The following is a description of a gene set: Mouse Gene Set: CUI_T_CELL_CD8_IL36A_RESPONSE_UP Cytokines mediate cell-cell communication in the immune system and represent important therapeutic targets. A myriad of studies have highlighted their central role in immune function, yet we lack a global view of the cellular responses of each immune cell type to each cytokine. To address this gap, the authors created the Immune Dictionary, a compendium of single-cell transcriptomic profiles of more than 17 immune cell types in response to each of 86 cytokines (>1,400 cytokine-cell type combinations) in mouse lymph nodes in vivo. A cytokine-centric view of the dictionary revealed that most cytokines induce highly cell-type-specific responses. For example, the inflammatory cytokine interleukin-1β induces distinct gene programmes in almost every cell type. A cell-type-centric view of the dictionary identified more than 66 cytokine-driven cellular polarization states across immune cell types, including previously uncharacterized states such as an interleukin-18-induced polyfunctional natural killer cell state. studied in species Mus musculus Genes positively differentially expressed in cell type: CD8+ T cell upon treatment with cytokine: IL-36α in mouse lymph nodes in vivo. from publication Cui A, Huang T, Li S, Ma A, Pérez JL, Sander C, Keskin DB, Wu CJ, Fraenkel E, Hacohen N (PMID 38057668), and this is the list of marker genes: Gbp9, U2af1, Cyc1, Rexo2, Eef1e1, Hnrnpa3, Ms4a4c, Hdgf, Shmt2, Lap3, Irf8, Atp5f1b, Snrpf, Sf3b5, Set, Psma3, Mrpl21, Stat2, Cct3, Rrp9, Ybx3, Larp1, Glrx3, Mphosph10, Anp32e (acidic nuclear phosphoprotein 32 family member E), Tomm5, Polr2f, Cycs (NCBI Gene Id 13063), Mdh2, Lsm7, Phb2, Hspd1, Eif4a1, Chchd1, Notch1, Hnrnpd, Atp5mk, Ppan, Psmb5, Gbp6, Gbp4, Strap, Psmg4, Icam1, Ndufa5, Tap1, Eif5a, Eif4ebp1, Lsm6, Eloc, Pole4, Nop56, Ptges3, Nudc, Glrx5, Wars1, Psmd14, Bzw2, Psmb6, Psmb8, Eif1ax, Ifi208, Clic4, Snrpd1, Elob, Fam162a, Mrpl52, Erap1, Hnrnpu, Pa2g4, Psmd7 (NCBI Gene Id 17463), Hspa8, Atic, Anp32b, Ywhae, Erh, Mrps28, Slc25a5, Vars1, Nifk, Timm9, Eif1a, Phgdh, Eprs1, Hsp90aa1, Rsl24d1, Ndufb2 (NCBI Gene Id 98925), Cox5b, Psat1, Ebna1bp2, Pes1, Psma4, Serbp1, Cxcl10, Dbnl, Slc7a1, Nop16, Igtp, Cd82, Cct5, Tap2, Isg15, Ddx21, Srsf3, Bst2, Ube2l3, Zfp593, Xaf1, Ifit1, Cox7c, Uchl3, Hspa5, Isg20, Mrto4, Rtp4, Dph3, Nfkbia, Tpm3, Nasp, Wdr43, Rars1, Naa20, Ifi47, Uqcr10, H2-Q4, Tuba4a, Lyar, Hspa4, Npm3, Cltb, Dkc1, Abce1, Ndufs6, Gpr18, Ube2m, Irf7, Snrpe, Eif2s2 (NCBI Gene Id 99435), Denr, Ran, Psme2, Znrd2, Ndufb4, Timm50, Pebp1, Nop2, Socs3, Mrpl51, Etf1, Irgm1 (NCBI Gene Id 15944), Eny2, Sarnp, Stat3, Eif3a (NCBI Gene Id 320318), Slc3a2, Pdcd11, Fkbp4, Llph, Vasp, Hsp90ab1, Dnaja2 (DnaJ heat shock protein family (Hsp40) member A2), Srsf7, Ppig, Eif3j1, Mrpl20, Mthfd2, Top1, Chmp4b, Calhm6, Caprin1, Cks2, Sp110, Eif3g, Dnajc2, Agfg1, Irf1, Lsm4, Gbp5, Txnl4a, Cct2, Snrpa1, Cacybp, Trafd1, Canx, Plac8, Tomm40, Pim1, Rsl1d1, Tnfrsf9, Sars1, Utp18, Bzw1, Gar1, Snrpd3 (NCBI Gene Id 78379), Ppp1r16b, Prmt1, Nampt, H2-T23, B2m, Edf1, Mat2a, Mif, Atp1a1, Gtf2f1, Romo1, Slc29a1, Samhd1, Arpp19, St13, Emc6 (NCBI Gene Id 70341), Mydgf, Gspt1, Kars1, Nme1, Psmb10 (NCBI Gene Id 19171), Srsf2, Mrpl17, Psmc5, Ccnd2, Nlrc5, Pgam1, Tkt, Mrpl36, Smc1a, Cox7b, Mettl1, Chchd2, Eif2ak2, Mrpl23, Gbp2, Cnbp, H2-K1, Ifi206, Tcp1, Tgtp1 (T cell specific GTPase 1), Ssrp1, Ssb, Pbdc1, Wdr83os, Lars1, Ppp1r14b, Eif5b, Aars1, Nhp2, Batf, Herc6, Prpf31 (NCBI Gene Id 70126), Ddx24, Mrpl19, Eif3b, Rrp1b, Sem1 (SEM1, 26S proteasome complex subunit), Rbmxl1, Ranbp1, Ly6e, Gbp8, Parp14, Tuba1b, Kcnq1ot1, Parp9, Mitd1, Trim12c, Nip7, Pals2, Psma5, Gzmb, Aurkaip1, Ndufab1, Alyref, Rbx1, Tmem167, Phb1, Ifrd2, Ybx1, Psmb9, Bax, Sumo2, G3bp1, Nop10, Cd274, Ltv1, Nars1, C1qbp, Pcbp1, Bccip, Mdn1, Pfdn2, Ldha, Aimp2, Eif6, Yars1, Ahsa1, Ifi35, Timm10, Mrpl30 (mitochondrial ribosomal protein L30), Cebpz, Pdap1, Sap18, Ptma, Lsm12, Prdx1, Odc1, Atad3a, Mndal, Nop14, Wdr12 (NCBI Gene Id 80478), Eif1 (NCBI Gene Id 217191), Ndufaf4, Ifi27l2a, Stat5a, Cars1, Gstp1, Uqcrq, Arid5b, Eif4g1, Oas3, Mapkapk2, Fabp5, Rbm8a, Mrpl12 (NCBI Gene Id 69758), Srm, Ddit3 (NCBI Gene Id 13198), Apex1, Pdcd5, Gnl3 (NCBI Gene Id 30877), Snrpb, Cops6, Bola2, Igfbp4, Ruvbl1, Ufm1 (NCBI Gene Id 99652), U2af2, Dtx3l, Lgals3bp, Tcof1, Tcf7, Cfdp1, Tars1, Eif4e, Noc2l (NOC2 like nucleolar associated transcriptional repressor), Atp5f1d, Psmd12, Aprt, Gpatch4 (G patch domain containing 4), Psma6, Ppia, Psma1, Rrs1, Pomp, Cct8, Ksr1 (kinase suppressor of ras 1), Fbl, Srsf6, Cdk6, Ftsj3, Mars1, Tmed5, Atp5mc1, Krtcap2, Atf4, Timm8a1, Hnrnpa2b1, Lman2, Snu13, Cox5a, Dcun1d5, Grpel1, Birc3, Lamp2, Gbp7, Dctpp1, Iigp1 (NCBI Gene Id 73042), Rcc2, Trp53, Hnrnpc, Mrpl15, Impdh2, Galk1, Psme1, Psmd6, Uqcc2, Ruvbl2, Tubb4b, Stip1, Trim30a, Ube2i, Hspa9, Ipo5, Taf10 (NCBI Gene Id 24075), Npm1, Gadd45g, H2-T22, Ly6a, Ppa1, Ifitm3, Gadd45b, Ncl, Snhg12, Gars1, Hnrnpab, Psmb2, Pim2, Tapbp (TAP binding protein), Tapbpl, Ssbp4, Sar1a (secretion associated Ras related GTPase 1A), Nolc1, Nop58, Gtpbp4 (GTP binding protein 4), Syncrip, Ddx39a, Dad1, Txn2, Fubp1, Rbm25, Iars1, Selenow, Eif3c, Socs1, Nmi, Ifit3, Banf1, Cct7, Psma7, Nsun2, Cd86, Timm13, Eif2s1, Cebpb, Ndufa12, Magoh, Tcerg1, Tmem147, Gzma, Hspe1 (heat shock protein 1 (chaperonin 10)), Snrpg, Psma2, Zbp1, Psme3, Polr2l, Apobec3 (apolipoprotein B mRNA editing enzyme, catalytic polypeptide 3), St6galnac4, Skp1, Bcl3, Stat1, Rnf213, Mybbp1a